Given this list of marker genes Ar, Pkn1, here is a description of the gene set: This event has been computationally inferred from an event that has been demonstrated in another species.<p>The inference is based on the homology mapping from PANTHER. Briefly, reactions for which all involved PhysicalEntities (in input, output and catalyst) have a mapped orthologue/paralogue (for complexes at least 75% of components must have a mapping) are inferred to the other species. species: Mus musculus part of: RHO GTPases activate PKNs Reactome Pathway: Activated PKN1 stimulates transcription of AR (androgen receptor) regulated genes KLK2 and KLK3 electronically inferred by orthology from the curated human pathway